The following is a description of a gene set: Human Gene Set: REACTOME_TFAP2_AP_2_FAMILY_REGULATES_TRANSCRIPTION_OF_CELL_CYCLE_FACTORS TFAP2 (AP-2) family regulates transcription of cell cycle factors studied in species Homo sapiens, and this is the list of marker genes: MYC, KDM5B, CDKN1A, TFAP2C, TFAP2A